Given this list of marker genes Cntnap2, Ptchd1, Kcnq2, Kcnq3, Fmr1, Tsc2, Pvalb, here is a description of the gene set: studied in species Mus musculus Mouse Gene Set: GOBP_INHIBITORY_CHEMICAL_SYNAPTIC_TRANSMISSION Synaptic transmission that results in an inhibitory postsynaptic potential.